Given this list of marker genes Lamp3, Arhgap39, Capza1, Kitl, Srsf6, Adamts15, Gria4, Fam53c, Kmt2c, Cd2ap, Sgk3 (NCBI Gene Id 72422), Ap4e1, Pgam5, Cfap47, Tmem44, Slain1, Dtx3l, Kbtbd6, Fhip2a, Akap9, Svep1, Rnf141, Rad23b, Frmd6, Mettl14, Nup210, Gpc6 (NCBI Gene Id 77735), Cdk14, Smad5, Mgat4c, Yy1, Acsl3, Efcab14, Plch1, Zcchc13, Myt1l, Hmgb2, Dusp11, Riok3, Sptlc2, Gm5800, Med7, Slc18b1, H3f3a, Aox2, Smad2, Scn3a, Perp, Rock1 (Rho-associated coiled-coil containing protein kinase 1), Cyfip2, Lrfn5, Letmd1, Nln, Arl5a, Tbx20, Ttc33, Scn7a, Tcerg1, Arl13b, Fstl5, Ammecr1, Tdrd6, Prkaa2, Hipk3, Zbtb44, Faf2, Tiam1, Plcb1, Secisbp2l, Myt1, Hlf, Sfr1, Cldn19, Plac8l1, Krtap4-1, Lrrc8a, Isl1, Cnksr3, Nr5a1, Ubr5, Pwwp2a, Tmem200a, Thap11, Cct3, Cnnm4, Ywhaq, Nsg1, Bnc2, Nap1l5, Ino80d, Lamp1, Osbpl3, Eif3e, Cep97, Nr2f2, Triap1, Phip, Snx16, Rbpj, Cip2a, Kat7, Acsl1, Pafah2, Slc5a7 (NCBI Gene Id 63993), Akirin1, Csnk1g3, Dip2c, Chml, Gopc (golgi associated PDZ and coiled-coil motif containing), Prkag2, Plag1, Dsc1, Braf, Elavl4, Ppil4, Nvl, Prnp, Catspere2, Vps41, Bmt2, Zfp385b, Gpatch8, Fgfr2, Zfp473, Grb10, Cul3, Gcc1, Usp1, Kcna2, Piga, Eloc, Ranbp17, Espnl, Cpsf6, Tpm1, Top1, Hipk1, Ash2l, Sik3, Gata3, Sobp, Tmem30a, Hormad1, Gpd1, Map1b, Pcf11, Frmpd3, Dhx36, Peak1, Denr, Pde1c, Pdgfc, G6pc1, 9230112D13Rik, H3f5, Plppr5, Carm1 (NCBI Gene Id 59035), Samd12, Klhl6, Cd1d1, Ociad1, Tbl1xr1, Galnt13, Ano1, Dipk2a, Entpd8, Rfx7, Zfp36l3, Cnot6l, Rprd2, Tob1, Creg1, Mosmo, Rapgef6, Sox5, Gspt1, Iqch, Dcun1d4, Banp, Med13l, Ndufv2 (NADH:ubiquinone oxidoreductase core subunit V2), Hps3, Anks1b, Slc12a1, Mtx3, Ppih, Adamts4, Col19a1, Fbxl5, Sox6, Brip1, Epm2aip1, Fos, Lipa, Plxna1, Ell2, Sox3, Tex9, Rras2, Pogz, Tspan32, Dpy19l1, Psg29, Ywhab, Taf4, Serp1, Mtnr1a, Bub3, Mon2, Arrdc3, Kpna4, Sesn1, Ccdc126, Cog6, Mapk8, here is a description of the gene set: studied in species Mus musculus from publication Chen Y, Wang X (PMID 31504780) Genes predicted to be targets of miRBase v22 microRNA mmu_miR_6417 in miRDB v6.0 with MirTarget v4 prediction scores > 80 (high confidence targets). Mouse Gene Set: MIR_6417